Given this list of marker genes JUN, EBP, TP53, PAX6, EGR1, STAT1, DHCR7-DT, SRF, GATA4, SMAD3, RABEP2, ATF2, here is a description of the gene set: Human Gene Set: YEMELYANOV_GR_TARGETS_DN Glucocorticoids are extensively used in combination chemotherapy of advanced prostate cancer (PC). Little is known, however, about the status of the glucocorticoid receptor (GR) in PC. We evaluated over 200 prostate samples and determined that GR expression was strongly decreased or absent in 70-85% of PC. Similar to PC tumors, some PC cell lines, including LNCaP, also lack GR. To understand the role of GR, we reconstituted its expression in LNCaP cells using lentiviral approach. Treatment of LNCaP-GR cells with the glucocorticoids strongly inhibited proliferation in the monolayer cultures and blocked anchorage-independent growth. This was accompanied by upregulation of p21 and p27, down-regulation of cyclin D1 expression and c-Myc phosphorylation. Importantly, the activation of GR resulted in normalized expression of PC markers hepsin, AMACR, and maspin. On the signaling level, GR decreased expression and inhibited activity of the MAP-kinases (MAPKs) including p38, JNK/SAPK, Mek1/2 and Erk1/2. We also found that activation of GR inhibited activity of numerous transcription factors (TF) including AP-1, SRF, NF-kappaB, p53, ATF-2, CEBPalpha, Ets-1, Elk-1, STAT1 and others, many of which are regulated via MAPK cascade. The structural analysis of hepsin and AMACR promoters provided the mechanistic rationale for PC marker downregulation by glucocorticoids via inhibition of specific TFs. Our data suggest that GR functions as a tumor suppressor in prostate, and inhibits multiple signaling pathways and transcriptional factors involved in proliferation and transformation. from publication Yemelyanov A, Czwornog J, Chebotaev D, Karseladze A, Kulevitch E, Yang X, Budunova I (PMID 17016446) studied in species Homo sapiens Transcription factors down-regulated in LNCaP cells (prostate cancer) by expression of GR off a lentiviral vector.